Given this list of marker genes NAPEPLD, RBP4, RBP1, RLBP1, ABCA4, OPN1MW, RDH12, TTR, RDH5, OPN1SW, OPN1LW, STRA6, LRAT, here is a description of the gene set: Retinoid cycle disease events Human Gene Set: REACTOME_RETINOID_CYCLE_DISEASE_EVENTS species: Homo sapiens